Given this list of marker genes Bpgm, Pmm1, Pmm2, Pgm3, Pgm2l1, Pgm5, Pgam1, Pgam2, Pgm2 (NCBI Gene Id 66681), Pgm1, here is a description of the gene set: Catalysis of the transfer of a phosphate group from one position to another within a single molecule. Mouse Gene Set: GOMF_INTRAMOLECULAR_PHOSPHOTRANSFERASE_ACTIVITY species: Mus musculus